The following is a description of a gene set: studied in species Mus musculus Mouse Gene Set: MIR_3064_3P from publication Chen Y, Wang X (PMID 31504780) Genes predicted to be targets of miRBase v22 microRNA mmu_miR_3064_3p in miRDB v6.0 with MirTarget v4 prediction scores > 80 (high confidence targets)., and this is the list of marker genes: Synj1, Dtymk, Fnbp4, Epha4, Nosip (nitric oxide synthase interacting protein), Ska3, Crtc1, Tvp23a, Gle1, Tmem268, Akr1c20, Rap2c, Mapre3, Fip1l1, Atxn7, 1700028K03Rik, Hsp90aa1, Dlx1, Has2, Cblb, Cfap91, Kcnj5, Atxn1l (NCBI Gene Id 78838), Sh3rf3, Rcan1, Taf7l2, Zfp386, Nploc4, Cacna1b, Bcas2 (NCBI Gene Id 99556), Zfp759, 2610008E11Rik, Hmgcll1, Atp12a, Zc3h4, Itih5, Tpp2, Zfp729a, Pramel34, Tcf4, Lig3, Bpifa3, Slc25a51 (NCBI Gene Id 77670), Gm773, Zfp953, Adcy1, Zbtb18, Cstf2t, Cdyl2, Dcun1d4, Ark2n, Rnf168, Serpini1, Or4d10c, Prkcsh, Gap43, Zfp738, Spta1, Taok1, Rbpj, Exoc3 (exocyst complex component 3), Tmprss13, Gpm6a, Dkk1, Foxn3, Slc1a7, Rnf128 (ring finger protein 128), Sema6d, AW554918, Snx30, Clip2, Kcnk10, Map4k3, Trim33, Glcci1, Timm21, Fam181a, Eef1a1, Zbtb11, Ddc, Tdrkh, Pogz, Tom1l2, Arhgef7, Wdr83, Mkrn1, Aox4, Smad3, Ccdc17, Calu, Calb1, Pramel47, Gcnt3, Stk17b, Ccni, Tcerg1, Gfpt2, Gpd1, Gata4, Napb, Tgds, Epha6, Parva (NCBI Gene Id 76528), Sec14l1, Pdcd7, Tcta, Rnf38, Appl1, Pramel48, Actr1a, Dok4